Given this list of marker genes UBE2Q1, INTS15, OTUB1, SMARCB1, THAP11, PSRC1, CDK2AP1, F8A1, WAC, SUMO2, TLE5, CTCF, NTAN1, HNRNPR, HDGF, PRPF18, PCBP1, MED28, TMEM131L, CS, HNRNPUL1, POLDIP3, here is a description of the gene set: studied in species Homo sapiens Human Gene Set: HOLLEMAN_PREDNISOLONE_RESISTANCE_B_ALL_UP Genes distinguishing prednisolone resistant and sensitive B-lineage ALL; here - genes up-regulated in the drug resistant samples. Childhood acute lymphoblastic leukemia (ALL) is curable with chemotherapy in approximately 80 percent of patients. However, the cause of treatment failure in the remaining 20 percent of patients is largely unknown. from publication Holleman A, Cheok MH, den Boer ML, Yang W, Veerman AJ, Kazemier KM, Pei D, Cheng C, Pui CH, Relling MV, Janka-Schaub GE, Pieters R, Evans WE (PMID 15295046)